The following is a description of a gene set: studied in species Homo sapiens Any process that activates or increases the frequency, rate or extent of protein localization to nucleolus. Human Gene Set: GOBP_POSITIVE_REGULATION_OF_PROTEIN_LOCALIZATION_TO_NUCLEOLUS, and this is the list of marker genes: TERT (NCBI Gene Id 7015), NMD3, NPM1, CACNB4, MCRS1, PINX1